Given this list of marker genes P4hb, Agr2, Ero1b, Dnajc10, Ero1a, Dnajc3, here is a description of the gene set: A protein folding process that takes place in the endoplasmic reticulum (ER). Secreted, plasma membrane and organelle proteins are folded in the ER, assisted by chaperones and foldases (protein disulphide isomerases), and additional factors required for optimal folding (ATP, Ca2+ and an oxidizing environment to allow disulfide bond formation). Mouse Gene Set: GOBP_PROTEIN_FOLDING_IN_ENDOPLASMIC_RETICULUM species: Mus musculus